The following is a description of a gene set: species: Mus musculus The breakage of covalent bonds to detach lipid groups from a protein. Mouse Gene Set: GOBP_PROTEIN_DELIPIDATION, and this is the list of marker genes: Atg4a, Atg4a-ps, Atg4c, Sirt6 (sirtuin 6), Atg4b (NCBI Gene Id 98652), Atg4d